Given this list of marker genes TCP1, CCT6A, USP7, MACROH2A1, PML, WRAP53, TERF1, ACD, GNL3, GNL3L, here is a description of the gene set: Human Gene Set: GOBP_REGULATION_OF_PROTEIN_LOCALIZATION_TO_CHROMOSOME_TELOMERIC_REGION Any process that modulates the frequency, rate or extent of protein localization to chromosome, telomeric region. studied in species Homo sapiens